Given this list of marker genes CEP350, FERRY3, CCRL2 (NCBI Gene Id 9034), C3orf18, RASGRP3, ELL3, DHRS4, ZNF706, NARS1, RFTN1, SPARC, IL10, ARL6IP5, EMC2, PKNOX1, UFSP2, CD81, BTN3A3, LAIR1, OPTN, ATP1B3, ZNF274, CFLAR, SLC16A6, KMO, CD80, CES1, LXN, LAMP2, MCM5, RHOQ, TBC1D16, SDC4, CXCL1, PLXNA1, DIPK1A, FADS1, TLR1, CTSK, CYP27A1, GBA1, HK2, RAB13, SCAMP2, LHFPL2, CYB5A, JAK1, CD209, PDXK, DHCR7, GRK3, CYBB, MREG, FBP1 (fructose-bisphosphatase 1), SQSTM1, LPAR1, ADAM28, CEP15, TNIP3, GFPT1, ALAS1, JAG1, CHPF2, LDLR (low density lipoprotein receptor), CCL8, AKT3, SMS, NQO1, CERT1, CLEC4E, NR1H3 (nuclear receptor subfamily 1 group H member 3), CASP3, RARRES1, APOO, NPC1 (NCBI Gene Id 4864), SLC5A3, YIPF6, POGLUT1, RER1, CD63, CCL2, CLIC2, NETO2, ANXA5, SLC12A8, FOXJ2, YWHAQ, ATP6V0E1, MT1G, SPRED2, TNS3, ATP13A3, APOE, LY75, VSIG4, SLC31A1, HLA-DRB4, MOB1A, TEX2, GLS, GRSF1, LPXN, PTGDS, SCCPDH, IL1R2, SPHK1, CD1E, CCSER2, PSTPIP1, SCARB2, FDX1, SCD, CPM, STAT1, IL6ST, OAZ2, SP140L, CD2AP, RIN2, FCGR1A, BIRC3, DMXL2, MCTP1, TCIRG1, EMP1, CCR5, MMP2, TBC1D13, PPIF, ALDH3A2, IL21R, RDX, CYP1B1, ACO1, RAB20, LITAF, CCL13, SLC36A1, CREG1, IFI6, OSBPL1A, SLC1A2, TNIP2, AQP9, KCNMA1, PLTP, CMKLR1 (chemerin chemokine-like receptor 1), METTL1 (NCBI Gene Id 4234), PLPP1, MTX2, GNS, CREBL2, PSMB5, EIF2S1, CSRP1, TUBA1C, SLC1A3, ACSL3, TFEB, CXCL10, SLC30A1, TNFAIP8, TMEM51, TRAF3, B4GALT5, SC5D, MPZL1, EBI3 (Epstein-Barr virus induced 3), CCR7, PINK1, VWA5A, ATP6V0A1, GPNMB, TNFAIP6, STOM, RGL1, SLAMF7, TNFRSF4 (TNF receptor superfamily member 4), BCAT1, GCLM, PRDX1, ABCG1, SNX10, CHI3L1, PPP1R12A, ILRUN, ACP5, LTBP2, EPB41L3, GGH, NECTIN2, ADAM12, MARCKS, EIF2B3, GOT2, FKBP4, PCK2, KLF9, SEC22B, DOCK4, DNPH1, INHBA, IRF4 (NCBI Gene Id 4592), SPP1, ZFYVE16, NPL, CHST15, ZNF804A, CCR1 (NCBI Gene Id 1230), ACAA2, EED, ANXA2P2, ARFGAP3, MATK, RBM47, SLC11A2, ATP6V1C1, ADAMDEC1, NRIP3, GLA, ATP9B, ST3GAL1, VDR, GSDME, NR4A3, TBC1D4, PDE4DIP, BCAP31, AKR1B1, CRTAM, NIT2, CALHM2, NCOA4, TM9SF4, CRYZ, GSR, PIR, ITPR1, SGMS1, HSPB1, REPIN1, ACAT1, TPST1, RAB38, SYNGR3, HSD11B1, MDM1, NAT1, KYNU, RAB9A, NKG7, CLEC5A, BET1, CRIM1, CCL19, ST8SIA1 (NCBI Gene Id 6489), FSCN1, SLC1A4, SGK1, PDCD6IP, CTSL, SLC3A2, DAD1, CD9, TSC22D1, MAOA, LYPD3, PVR, TRAF1, CTBS, CCL18, ARHGAP22, SNTB1, DNAJB6, CXCL3, GPR137B, SLC35B1, ASAH1, LILRB4, TXN, CXCL9, CXCL5, MFHAS1, CCND1, LAMP3, IL18, NCOA3, TMEM97, TGM2, RAB8B, ROBO1, LEPROT, SERPINF1, PACSIN2, GABBR1, TFRC, RAMP1, ME1, RUNX1, GPD2, MED14, PSMG1, DYNC1LI1, CSF2RA, ATP6V1H, N4BP1, EEF1AKMT3, FTH1, FAH, PIGP, CERS6, ENTPD1, IL1B, TMEM184C, LMBR1L, LYSET, IDO1, MGLL, DUOX1, NDUFS2, VAT1, SLC29A3, C3, ELOA, SEPHS1, AKR1C1 (NCBI Gene Id 9418), CCL3, CSTF3, STK17A, EPB41L2, VNN1, CCL17, HDAC2, APOC1, HEXB, MYOF, SGPL1, RAB3GAP1, PPARD, GNA12, ANXA2, CYP27B1, MT1F, CD1B, PLGRKT, MT1X, SOD2, MMP9, PHYH, PLOD3, MRPL35, EMC7, ENSA, G6PC3, LAMP1, CNPY2, IL1R1, CCL15, GADD45G, NIBAN1, PLA2G7, SERPINE1, PSD3, TBC1D1, SLAMF1, TM6SF1, C3AR1, CPD, DUSP5, ASMTL, SDC2, DHCR24, PLPP3, MT2A, TCEAL9, LGALS3, CD84, EMILIN1, SLAMF8, ANOS1, SLC43A3 (NCBI Gene Id 55543), C1S, SLC7A11, UBAP2L, NDRG1, SUZ12, CD58, CCL22, TRIP10 (NCBI Gene Id 9322), PSEN2, DPAGT1, CTSD, ABCC3, C1QA, MT1H (NCBI Gene Id 727730), FASTKD1, RDH11 (NCBI Gene Id 51109), FZD5, CDS2, CD59, CD47, GM2A, TMBIM6, NDP, IL1A, FILIP1L, TCF3, ST3GAL6 (ST3 beta-galactoside alpha-2,3-sialyltransferase 6), MITF, DAB2, SQLE, TFG, NRP1, TIMP2 (TIMP metallopeptidase inhibitor 2), BHLHE41, MDH1, MMP12, DCSTAMP, SUN2, EMG1, TSPAN3, here is a description of the gene set: species: Homo sapiens Genes up-regulated in peripheral blood monocytes by HGF. Human Gene Set: RUTELLA_RESPONSE_TO_HGF_UP Several hematopoietic growth factors, including interleukin-10 (IL-10) and transforming growth factor-beta1 (TGF-beta1), promote the differentiation of tolerogenic dendritic cells (DCs). Hepatocyte growth factor (HGF) is a pleiotropic cytokine whose effects on human DC differentiation and function have not been investigated. Monocytes cultured with HGF (HGFMo) differentiated into accessory cells with DC-like morphology, released low amounts of IL-12p70 and up-regulated IL-10 both at the mRNA and at the protein level. Upon activation with HGFMo, allogeneic CD4+CD25- T cells expressed the T regulatory (Treg)-associated transcription factor FoxP3, proliferated poorly, and released high levels of IL-10. Interestingly, blockade of surface immunoglobulin-like transcript 3 (ILT3) on HGFMo or neutralization of secreted IL-10 translated into partial restoration of T-cell proliferation. Secondary stimulation of HGFMo-primed CD4+ T cells with immunogenic DCs differentiated with granulocyte-macrophage colony-stimulating factor (GM-CSF) and IL-4 from monocytes of the same donor resulted in measurable T-cell proliferation. HGFMo-primed CD4+ T cells significantly inhibited the proliferation of naive CD4+CD25- T cells in a cell-contact-dependent manner. Finally, DNA microarray analysis revealed a unique gene-expression profile of HGF-activated monocytes. Collectively, our findings point to a novel role for HGF in the regulation of monocyte/DC functions that might be exploited therapeutically. from publication Rutella S, Bonanno G, Procoli A, Mariotti A, de Ritis DG, Curti A, Danese S, Pessina G, Pandolfi S, Natoni F, Di Febo A, Scambia G, Manfredini R, Salati S, Ferrari S, Pierelli L, Leone G, Lemoli RM (PMID 16527888)